The following is a description of a gene set: DNA methylation is essential for normal development and has been implicated in many pathologies including cancer. Our knowledge about the genome-wide distribution of DNA methylation, how it changes during cellular differentiation and how it relates to histone methylation and other chromatin modifications in mammals remains limited. Here we report the generation and analysis of genome-scale DNA methylation profiles at nucleotide resolution in mammalian cells. Using high-throughput reduced representation bisulphite sequencing and single-molecule-based sequencing, we generated DNA methylation maps covering most CpG islands, and a representative sampling of conserved non-coding elements, transposons and other genomic features, for mouse embryonic stem cells, embryonic-stem-cell-derived and primary neural cells, and eight other primary tissues. Several key findings emerge from the data. First, DNA methylation patterns are better correlated with histone methylation patterns than with the underlying genome sequence context. Second, methylation of CpGs are dynamic epigenetic marks that undergo extensive changes during cellular differentiation, particularly in regulatory regions outside of core promoters. Third, analysis of embryonic-stem-cell-derived and primary cells reveals that 'weak' CpG islands associated with a specific set of developmentally regulated genes undergo aberrant hypermethylation during extended proliferation in vitro, in a pattern reminiscent of that reported in some primary tumours. More generally, the results establish reduced representation bisulphite sequencing as a powerful technology for epigenetic profiling of cell populations relevant to developmental biology, cancer and regenerative medicine. Genes with high-CpG-density promoters (HCP) that have no histone H3 methylation marks in neural precursor cells (NPC). Human Gene Set: MEISSNER_NPC_HCP_WITH_H3_UNMETHYLATED from publication Meissner A, Mikkelsen TS, Gu H, Wernig M, Hanna J, Sivachenko A, Zhang X, Bernstein BE, Nusbaum C, Jaffe DB, Gnirke A, Jaenisch R, Lander ES (PMID 18600261) species: Mus musculus, and this is the list of marker genes: ITGA4, FUT4, FAM110C, PLBD1, NTSR1, TAF9B, VSX2 (NCBI Gene Id 338917), C1orf115, GLP1R, RARB, PHF1, GLDN, AARD, TNFRSF25, SYCE2, ANKRD53, MYO5C, ARSJ, BIRC3, BFSP1, CUL9, MAEL, SPEG, PAPOLB, PLLP, ANXA11, KCNK4, HENMT1, EOGT, AMN (amnion associated transmembrane protein, NCBI Gene Id 81693), HTATIP2 (NCBI Gene Id 10553), ADGRE5, PROM2, CRACR2B, NPEPL1, GCA, NR4A3, DKK3, GYPC, PDLIM2, SYCP1, IL27RA, PKDREJ, PIK3R5, TAF7L, GSAP, TBR1, RBM43, LAMC2, METTL24, ARTN, CCN3, DDIT4L, MCUB, FLYWCH2, KCNH7, CTSZ, DUSP26, KBTBD12, P2RX5 (purinergic receptor P2X 5), FGF17, GPX7, SLC47A1, SP5, LHX9, CAMKV, DHH, SLC2A12, NPAS4, B3GNT8, CD83, STAT5A, MANSC1, VSTM4, LIN7B, RIPOR2, MOXD1, TMC8, CDCP1, EPPK1, CCDC125, SLC25A31, ITGB4, NRXN2, PLSCR4 (NCBI Gene Id 57088), GNG13, PGM5, DPEP3, DRGX, DMC1, KDF1, ECHDC2, GPR156, RASEF, MMP14, CDKL1, FADS6, CA4, CWH43, LRRC15, DNAJB3, ENTPD2, CAVIN3, NGF, RIC3, LARGE2, ALDH1B1, MYOCD, SLC18A2, NIBAN1, SCX, TRIM25 (tripartite motif containing 25), NCMAP, CDO1, ASS1, SLC7A10, TDRD6, TMEM54, MMP2, SLC39A8, OLFM2, PRSS50, RPP25, RNF225, LARP6, ABCB1, CCDC158, CD164L2, CDX1, ECE2, PRKAR1B, DCDC2, LBX2, RASSF10, LEKR1, HS3ST2, OLIG3, NSMCE3, ARSI, AGBL2, SHD, RAB42, DHTKD1, DNAAF6, FGF22, ADGRV1, SHROOM1, CALN1, BARHL1, SLC47A2, GSN, SLC34A2, CIMAP1B, NAPRT, TERB1, CSPG4 (chondroitin sulfate proteoglycan 4), CYGB, MAB21L1, MESP2, DAZL, LAMC3, INSRR, SOX7, ABTB3, SSTR4, SHFL, SYCP3, SLC44A3, NDRG2, QRFPR, TPM2, PCSK9, GNA14, TUBG2, RHBG, OMP, PTGIS, MARVELD2, HEYL, GPR12, EVA1B, TMEM37, CLDN5, F11R, PLEKHG6, DPP6, MAL2, NOX4, TRIM47, STK32A, SLIT1, TMPRSS2, CLDN11, SLC16A3, CLIC6, PRRG3, PPM1J, LPCAT2, PTGER2, LTBR, EMID1, KCNA6, AP1S3, TRPM6, FGFR4, SCARF2, SDR39U1, IGFBP6, PARVB, LOXL1, ARHGEF4, RARG, PCTP, KREMEN2, HSF5, CLDN3, GFRA2, DDX4, THEM7P, FGF20, LHX3, SYCP2 (NCBI Gene Id 10388), CASTOR1, C9orf50, HIF3A, SCIN, CAMKK2, CBLC, MSH4, KCP, MPV17L, TRIM58 (tripartite motif containing 58), RNH1, GSDMD, CACNG2, PPP1R3B, RAB3B, DBX2, NAGS, DMRTA1, FOXI2, HTR2C, ANO1, SLC22A4, DSG2, DOC2B, BASP1, OSMR, EZHIP, TNFRSF10B, THBD, HORMAD1, EEF1A2, CYP24A1, THEMIS2, HSPA12A, SYT16 (synaptotagmin 16), P4HTM, RAX, ABCC8, SGK3, DRD5, P2RX2, PARP14, RMDN2, MGARP, CHRNA3, ADCY7, CD302, CHST6, B3GNT3, HTRA3, HSF4, AFAP1L2, TUBB4A, PCNX2, HAND1, MATN4, KCNK13, STAC (SH3 and cysteine rich domain), SLC6A11, SPMAP2L, FLOT2, TNFAIP2, RASD1, TFCP2L1, TDRD1, ASIC2, LINGO3, NLRX1, KCNIP1, ARHGAP27, SLC6A2, MMP25, MINAR1, MCOLN2, KL, IRAK3, GNMT, FAR2, IRX4, AFAP1L1, SLC13A3, SLC16A11, CLDN7, ALOX12, L3MBTL4, GMIP, SYBU, SPTBN4, AP1G2, SPMIP6, GUCY2D, WDR86, PRR15, VSIR (NCBI Gene Id 64115), CYP4V2, ILDR1, LTB4R2 (NCBI Gene Id 56413), KY, MAPK13, GRHL2 (grainyhead like transcription factor 2), SH3D21, REM1, SPAG16, PITPNM1, ITPRIPL2, TSNAX, PHOX2A, LOXL4, PRLHR, CLDN4, BCAT1, ESYT3, TSPAN2, NGB, KRT19, CPNE7, F2RL1, PRRT3, ABCB9, SPAG6, PDE4DIP, IFITM10, NIPAL2, BSPRY, FAM83G, CYP4F22, ADAD1, ZNRF4, DMGDH, ADSS1 (NCBI Gene Id 122622), EPS8L2, CST6, ACOT6, SPO11, RASL10A, TMEM30B, THBS4, SLC9A3, CYP2R1, ANO5, SLC1A1, MFSD6L, RIN3, SELENOV, SOWAHA, PHETA2, CMTM7, ATP2A3, NTSR2, CRISPLD2, FSTL3, PKP1, NODAL, IL17RB, HHAT, FADS3, FGF16, TDH, NPY5R, DSC2, FBRSL1, CCDC106, RGCC, GALR1, CDK18, S1PR3 (sphingosine-1-phosphate receptor 3), FAH, EMILIN3 (elastin microfibril interfacer 3), HTRA4, SEMA4F, PAQR5, LGALS3, TMCO4, CRPPA, GJB6, TMEM59L, MARVELD3 (NCBI Gene Id 91862), FABP3 (NCBI Gene Id 337956), SSTR1, ESRP2, SLC30A2, NPB, OXTR, FBLN7, CORIN, C5orf47, TTC22, GPX3, GALNT6, TACR3, PSD2, RBMXL2, NAP1L5, EHBP1L1, FBXO17, KRT18, PRKAG2, KCNK9, TMEM171, PRDM14, KCNJ6 (potassium inwardly rectifying channel subfamily J member 6), HTR1F, GCNT1, GPR83, LIAT1, LPL, CYBA, TNXB (tenascin XB), IRF6, ACTL7B, NIPAL4, CXCL16, MAP10, RASGRF2 (NCBI Gene Id 89993), CAVIN1, WNT10B (NCBI Gene Id 82499), DLGAP1, ISYNA1, DES, GRB10, ZNF641, CHMP4C, SMC1B, ABCG4, PLCD1, PCDHGA11 (protocadherin gamma subfamily A, 11), OXT, FAM163A, AQP3, CASP8, NAA11, C1orf216, CLVS2, KLHL14, IL12RB2, CTSH, MEX3A, TACSTD2, ST6GALNAC2, SOWAHD, ADORA2A, SSH3, TTC38, BHLHA15, SPATA32, CERKL, GRIN3B, NTF3, GPR26, C20orf144 (chromosome 20 open reading frame 144), KCNG1, LYPD6B, TCF20, LGI3, PDHA2, DUSP9, KLK8, SLC25A21, PKIB, LHFPL5, HEBP1, GFRA3, SHISAL2B (shisa like 2B), NLGN2, OR2I1P, PRORSD1P (prolyl-tRNA synthetase associated domain containing 1, pseudogene), COL8A2, EFNB3, RNF17 (ring finger protein 17), PPL, GRIN2C, GABRQ, IRS3P, BCL3, CCN2, PHACTR3, GAL, ADGRG2, FKBP6, SLC5A5, SCARA3, EVC, TRIM36, THSD7B, GPR176, MYCN, NCOA4, CHCHD10, CPNE9, WT1, COL26A1, ST14 (NCBI Gene Id 6768), EDN3, TFAP2E, AP1M2, SLC45A1, SLC26A8, WNT3, SHROOM3, ACP7, SEC31B, RHCG, SHTN1, GIPC2, MTARC1, SCNN1B (sodium channel epithelial 1 subunit beta), SLCO2A1, USH1G, ADAMTSL5, BHLHA9, MMP23B, GRIN2A, PDGFD, MPIG6B, KRT7, MYOD1, BMP8B, VAMP5, RIPPLY3, MOCOS